Given this list of marker genes CASKIN1, FGFR1, PRICKLE1, LATS1, PTPN13, CLSTN3, LRRC4B, SEMA4A, LRFN1, VSTM5, PTPRS, LRFN4, GRID2, CRIPT, LRRTM2, IL1RAP, CBLN1, PTPRD, PTK2B (NCBI Gene Id 5748), WNT7A, ABI3 (NCBI Gene Id 51225), here is a description of the gene set: studied in species Homo sapiens Any process that modulates the frequency, rate or extent of excitatory synapse assembly. Human Gene Set: GOBP_REGULATION_OF_EXCITATORY_SYNAPSE_ASSEMBLY